The following is a description of a gene set: Reactome Pathway: NAGS variants cause NAGS deficiency part of: Diseases of the urea cycle studied in species Homo sapiens N-Acetylglutamate Synthase Deficiency (NAGSD) is a rare autosomal recessive urea cycle disorder caused by a deficiency of the mitochondrial enzyme N-acetylglutamate synthase (NAGS). This enzyme is essential for activating carbamoyl phosphate synthetase I (CPS1), the first and rate-limiting enzyme in the urea cycle. Without NAGS, CPS1 is inactive, preventing the initiation of the urea cycle and leading to accumulation of ammonia (hyperammonemia)., and this is the list of marker genes: NAGS